The following is a description of a gene set: Genes up-regulated in CD8 T cells at day 30: memory cells after acute infection with LCMV-Armstrong versus exhausted cells during chronic infection with LCMV-Clone 13. from publication Doering TA, Crawford A, Angelosanto JM, Paley MA, Ziegler CG, Wherry EJ (PMID 23159438) During acute viral infections, naïve CD8+ T cells differentiate into effector CD8+ T cells and, after viral control, into memory CD8+ T cells. Memory CD8+ T cells are highly functional, proliferate rapidly upon reinfection and persist long-term without antigen. In contrast, during chronic infections, CD8+ T cells become “exhausted” and have poor effector function, express multiple inhibitory receptors, possess low proliferative capacity, and cannot persist without antigen. To compare the development of functional memory T cells with poorly functional exhausted T cells, we generated longitudinal transcriptional profiles for each. species: Homo sapiens Human Gene Set: GSE41867_MEMORY_VS_EXHAUSTED_CD8_TCELL_DAY30_LCMV_UP, and this is the list of marker genes: DYNLRB1, DOK1, SCLY, VSTM4, PLEK, KIF9, FASLG, STAT2, PIAS1 (protein inhibitor of activated STAT 1), CD99L2, PSME2, TNNI2, UBALD2, FBXO7, ATP8A2, CTSG, DAXX, LIMD2, SLC15A3, TMEM140, SENP8, CD84, MAP3K5, HHEX, TMEM17, ARHGAP25, FGF13, LRRC8E, IL18, EPPK1, TBC1D21, CXCR6, DUSP2, TBK1, ARHGEF6, GBP7, ITGB5, RRAD, ADGRD1, ANXA1, CEBPD, SERPINB9, RNASEL, GGPS1, ZNF513, LEAP2, CEP120, IFT25, CALHM6, FNBP1, CORO2A, MS4A6A, OARD1, SERPINB6, PCNX2, WASHC3, PRTN3, TLR4, ANKRD42, SESN1, NCF2, HELZ2, MMAA, HMGN3, ATP8B4, GSAP, IRF1, LRRN4, DENND2B, TFEC, CFAP126 (NCBI Gene Id 257177), CNN3, ANKRA2, SPI1, TRIM5, MPV17L, SERPINI1, SLITRK6, OCIAD1, PLSCR3, USP8, IQSEC1, CSRNP1, ATP8A1, CD83, TRIM26, IL18RAP (NCBI Gene Id 8807), TDRD7, DSC2, ZFYVE26, CYBB (cytochrome b-245 beta chain), TASL, MICAL1, PTPRZ1, IFIT2, NLRC5, DAAM1, RASGEF1B, HSD11B1, TBC1D22B, HINT3, COA5, CTSS (NCBI Gene Id 50653), FBXO4 (NCBI Gene Id 55087), HSPA1A, SETDB1, LGALS9B, LRRC15, TRIM21, CARD6, RNF31, BCL7B, ICOSLG, TMED6, ADAR, LAMTOR4, TLR7, LAT2, SERPINE2, TRIM14, AP3M2, SAMHD1, DAPP1, TOR3A, ATP10A, LCK, CD40, IL12RB1, MPO, MTUS1, NFU1, NOXRED1, MLLT6, CHMP4B, GCNT1, RNF157, ALS2, NIT2, WDR37, TLR1, ADGRB2, CSF2, IRF8, USP43, CD244, ZSWIM2, IFT22, PARP14, MITD1, F2R, GPR65, CASP1, SOCS1, NQO2, DENND4A, STIM2, ITGAL, MSRB2, VPS54, SUCO, ETNK1, ICAM1, SLC6A12, HSH2D, RAB5C, DCAF8, BCAT1, MYCBP2, GBP4, IFNG, PHF23, NCEH1, SERPINB1, ARHGAP30 (Rho GTPase activating protein 30), LYST, PGLYRP2, SGK3, TTYH3, BMP2, PHLPP1, LTB, AIDA, CYP4F3, GIMAP6, MYBPC2, NT5C3A, RNF145, GPR18, TSPAN14, MAF, CCDC90B, BATF2, MCOLN3, OAS3, RGS17, JUN, TAPBPL (TAP binding protein like), ARPP21, LFNG